The following is a description of a gene set: Acts as a trigger for a pattern specification process when present at a specific concentration within a gradient. Human Gene Set: GOMF_MORPHOGEN_ACTIVITY species: Homo sapiens, and this is the list of marker genes: WNT1, MICOS10-NBL1, GREM1 (gremlin 1, DAN family BMP antagonist), NBL1, NODAL, CER1, SHH, DAND5